Given this list of marker genes Tcf7l2, Tle2, Tcf7l1, Tcf7, Tle4, Tle1, Lef1, Ctbp1, Ctbp2, Tle3, here is a description of the gene set: species: Mus musculus Mouse Gene Set: REACTOME_REPRESSION_OF_WNT_TARGET_GENES Repression of WNT target genes